The following is a description of a gene set: species: Mus musculus Mouse Gene Set: GM6710_GM14391_UNIPROT_Q8C1K5_UNREVIEWED_TARGET_GENES Genes containing one or more binding sites for UNREVIEWED (Gm6710 or Gm14391) in their promoter regions (TSS -1000,+100 bp) as identified by GTRD version 20.06 ChIP-seq harmonization. from publication Yevshin I, Sharipov R, Kolmykov S, Kondrakhin Y, Kolpakov F (PMID 30445619), and this is the list of marker genes: H1f11-ps, Mxd3, Ccndbp1, Tet1, As3mt, Mroh1, Gm22122, Anapc15, Slc39a11, Gnl3, Usp14 (ubiquitin specific peptidase 14), AA986860, Tor1aip1, Recql, Arl2bp, Rfx2, Ivns1abp, Ndfip2, Lysmd1, Xab2, Atp6v0b, Zfp438, Il4, Gm13998, Tsc22d4, Maf, Cox6c, Tor1aip2, Snord52, Ankrd40, Misp3, Gm24665 (NCBI Gene Id 115486155), Tm4sf5, Tpk1, Eif4a-ps4, Mgst3, Slc4a1ap, Uap1l1, Iho1, Ctnna3, Fzd10os, Mzf1, Cep95, Uba52, Gm25916, Gm11478, 2500002B13Rik, Syngr4, Thap6, Arrdc3, Rabl6, Ribc2, Mrps10, Elp5, Pou6f1, Platr22, Atp8b3, Gm6985, Synj2, Vcp, Cib1, Ebf2, Gm7094, Myo10, Ociad1, Bcar3, Ces1d, Bnc1, Dnajb2, Mdm4-ps, Git2, Inpp5f, Mkks, Zbtb45, Dhps, Gse1 (genetic suppressor element 1, coiled-coil protein), Sap30 (NCBI Gene Id 60406), Gm12125, Adamts2, Capns1, Srsf1, Stag2, Zfp395, Gm9506, Btbd19, Carhsp1, Hvcn1, Uvrag, Rell1 (RELT-like 1), Il17rd, Gpr62, Onecut2, Wfs1, Usb1, Gm10073, Rplp2, Kit, Kcnk6, Gm24068, Ddx20, Ltbp3, Gm12740, Foxc1, 5430401F13Rik, Eef1a1, Slain1, Gm25217, Cracr2b, Zdhhc5, Mtus2, Mpzl2, Prpf19, Yars1, Ubtfl1, Trap1, Kazald1, Gm11665, Ube2i, Gm23382, C330002G04Rik, Mbtps2, Nhlrc2, Rora, Glo1-ps, Gm11292, Fbxl22 (F-box and leucine-rich repeat protein 22), Rpl5, Smtn, B230322F03Rik, Atg2a, Dclre1a (NCBI Gene Id 80616), Mdk (midkine), Zfp319, Tspyl2, Trpc4ap, Gm8398, Ift140, Atxn1l, Csf1r, Tram1, Fscn1, Eif5a, Pick1, Stradb, Ogt, Ercc6l, Gm27343, Mir6405, Phex, Slc9a8, Sass6, Nmnat2, Gm29243, Rpl26, Rnf125, Gm23390, Lrrc46, Ddb2, Cyp4a28-ps (NCBI Gene Id 81908), Bcas2, Kat2b, Gm6872, Ash2l, Ints5, Ino80dos, Actr8, Frat1, Uhrf1, Cpne1, Ighg1, Gm8213, Ing3, Psma3, Plxnd1, Klk8, Nbr1, Tpd52l2, Tyw1, Nudt19, Mdc1, Sumf2, Gm12245 (predicted gene 12245), Nudt5, Tpt1, Sun1 (Sad1 and UNC84 domain containing 1), Gm25930, Lsm12, Kcnip2, Zfat, Psmd7, Nsun5, Virma, 1700023H06Rik, Myo15a, Gm15610, Edrf1, Gm12333, Mettl13, Dsc1, Gm11771, Flvcr1, Luc7l2, Gtf2e2, Scnm1, Tbc1d10b, Atp8b4, Gm9887, Slc38a8, Rdm1, Kntc1, Plekha6, Zbtb25, Gm2990, Tshz1, Hspa8, Plcxd2, Nktr, Gm10532 (NCBI Gene Id 100038353), Eci1, Tatdn2, Nme4, Rpl7, Extl1, Dync1h1, Tfdp1, Gm13110, Lhx4, Rnf6, Fbxw27, Ywhag, Slc25a38, Apom, Ckap2, Gm16437, Gpr107, Tmem143, Smad7, 4933440N22Rik, Mta2, Cltc, Zfp747l1, Cngb1, Snhg17, 2010109A12Rik, Thpo, Ccdc65, Ptbp1 (NCBI Gene Id 19205), Snta1, S100pbp, Hsp90ab1, Pcdhgc5, Ddx23, Ino80d (INO80 complex subunit D), Rnf2, Fancd2, Cbfb, Eif3k, Dnmt3a, Xpnpep1, Mrpl10, Trim67, Pcdh19, Mir1199, Slx4ip, Trp53cor1, Atf7ip, Togaram2, Thrap3, Hspa9, Ppp2r5c, Irf8, Psmb3, Ccdc116, Gadd45b, Rnf121, Platr27, Gm15651, 1110002J07Rik, Vps72, Exosc1, Rps6-ps3, Psmb6, Foxn3, Ramp2, Fam83c, Atrnl1, 2810407A14Rik, Cenpi, Cryl1, Tjp2, Nek9, Mir3965, Rex1bd, Dnajc11, Afg3l1, Gm4847, Gm16580, Inpp5k, Gm7831, Eif1ad8 (NCBI Gene Id 666806), Rcbtb1, Sec24c, Zbtb1, Zfp809, Smc1b, 4930515G01Rik, Fmc1, Gm25482, Gm4285, 9530068E07Rik, Gm5764, Rpl38, Fcgr2b (Fc receptor, IgG, low affinity IIb), Sag, Slc18a3, A330102I10Rik, Agap3, Lrrc23 (NCBI Gene Id 70946, leucine rich repeat containing 23), Srebf1, Tcirg1 (NCBI Gene Id 27060), Gm28874, Inpp5b (NCBI Gene Id 16330), Hmgb1, Trp53rka, Gm28836, Kctd3, Itgb5, Unc119b (unc-119 lipid binding chaperone B), Emc3, Zmynd11 (NCBI Gene Id 66505), H4c16, Fzd10, Clec2d, Ly6g, Gm12610, Mfsd5, Ninj2, Park7 (NCBI Gene Id 57320), Metap2, Hsd3b7, 1110038B12Rik (RIKEN cDNA 1110038B12 gene), Ift172, Mtfr1, Zfp36l1, Zmynd12, Gm24204, Smc3, Mis18bp1, Scpep1, Sec14l5, Gm22881, Gm20544, Hexim2, Degs2, Ddx47, Slc25a19, Mlxip, Pou2f2, Pias3, Lbr, Ube2c, Shmt1